The following is a description of a gene set: Human Gene Set: HEDENFALK_BREAST_CANCER_BRACX_UP from publication Hedenfalk I, Ringner M, Ben-Dor A, Yakhini Z, Chen Y, Chebil G, Ach R, Loman N, Olsson H, Meltzer P, Borg A, Trent J (PMID 12610208) In the decade since their discovery, the two major breast cancer susceptibility genes BRCA1 and BRCA2, have been shown conclusively to be involved in a significant fraction of families segregating breast and ovarian cancer. However, it has become equally clear that a large proportion of families segregating breast cancer alone are not caused by mutations in BRCA1 or BRCA2. Unfortunately, despite intensive effort, the identification of additional breast cancer predisposition genes has so far been unsuccessful, presumably because of genetic heterogeneity, low penetrance, or recessive/polygenic mechanisms. These non-BRCA1/2 breast cancer families (termed BRCAx families) comprise a histopathologically heterogeneous group, further supporting their origin from multiple genetic events. Accordingly, the identification of a method to successfully subdivide BRCAx families into recognizable groups could be of considerable value to further genetic analysis. We have previously shown that global gene expression analysis can identify unique and distinct expression profiles in breast tumors from BRCA1 and BRCA2 mutation carriers. Here we show that gene expression profiling can discover novel classes among BRCAx tumors, and differentiate them from BRCA1 and BRCA2 tumors. Moreover, microarray-based comparative genomic hybridization (CGH) to cDNA arrays revealed specific somatic genetic alterations within the BRCAx subgroups. These findings illustrate that, when gene expression-based classifications are used, BRCAx families can be grouped into homogeneous subsets, thereby potentially increasing the power of conventional genetic analysis. Up-regulated genes distinguishing between two groups of non-BRCA1/BRCA2 breast tumors (BRACx): group A vs group B. species: Homo sapiens, and this is the list of marker genes: COL6A2, SPRY1, MCF2, ADNP, PNOC, ATP5F1B, RPL31, CHPF, RPS13, RPL19, RPS4X, JUNB, RPP30, CYP1A1 (NCBI Gene Id 1543), RPS5, KDM6A, UBA52, TANK, RPL15